Given this list of marker genes SUCLG1, PI4KA, RAB11B, SRPK3, FUCA1, NPC2, ATCAY, GRIN1, NODAL, ATXN1, PRRT2, NDUFA12, NUP54, HPRT1, HIVEP2, SLC25A42, RNU7-1, PLA2G6, STXBP1, VPS16, NDUFA2, SOX10, PI4K2A, DHDDS, NDUFS8, DNAJC13, NEUROD2, FXN (frataxin), OCLN, PIGQ, NAA60, SLC6A3, AFG2A, CLTC, COL25A1, PCCB, COASY (NCBI Gene Id 80347), TWIST1, ADCY5, CHD8, ACSF3, TMEM106B, CDKL5, ATP7B, ATPAF2, HTT, ECHS1, B3GALT6, FOXH1, CLPB, CACNA1B, GABBR2, COPB1, EIF2AK2, SIX3, NDUFAF6, RNASEH2B, ACADS, UFC1, FARS2, ARV1, SIGMAR1, SNORD118, PLCH1, SCN1B, TACSTD2, SETX, LRRK2, SPTAN1, NDUFS7, STX16, PCBD1, SDHD, ATP5PO, NAA10, BSCL2, NADK2, DMXL2, AP3D1, CPLX1, GRIK2, PODXL, GRM7, EARS2, RNASEH2A, TGM6, GLB1, KCNC3, PLAA, CYB5A, GSX2 (NCBI Gene Id 170825), GRIA2, VPS13C, TXN2, ZIC2, DISP1, HACE1, PCGF2, TUBB2B, CACNA1E, WDR73, CUX2, ACTB, SDHA, GLE1, SLC19A3, ALG3, PDHX, CRLS1, SQSTM1, TRIT1, CYB5R3, CEP85L, TMEM240, POLR3A, MICU1, SPTBN1, TGIF1, ALDH6A1, SLC2A1, MMADHC, CACNA1A, LTBP2, H4C5, CHN1, SPG11, MAPT, TRAPPC11, PHLDB1, COL6A3 (NCBI Gene Id 1293), PTCH1, ACER3, PPFIBP1, GCH1, NKX6-2, PRKRA (NCBI Gene Id 94716), HECW2, ATM, EIF4G1, HINT1, MAFB, NDUFS1, TTBK2, MARS2, PRDX3, SHQ1, MPV17, COLEC11, GIGYF2, ARSA, GCDH, FITM2, LIPT1, IFIH1, SLC6A8, MT-ND3, CYP27A1 (cytochrome P450 family 27 subfamily A member 1), TTPA, AP4E1 (NCBI Gene Id 23431), MT-TT, MECR, TUBB4A, SLC2A3, AP4B1, CBS, STARD7, HPDL, ZC4H2, POLR3B, KIF21A, SLC25A22, TRPV4, COL6A1, IMPDH2, KCNN2, ABCD1, ATP5MK, SLC44A1, TRPM3, GNAL, GCSH, FA2H, SPR, CDC40, ATP13A2, CRH, POLR1D, REPS1, CARS2, AFG2B, PSAP, TANGO2, PARK7, TSEN54, AQP4, PPP2R2B, POLR1B, ALS2, PURA, SLC13A5, GRIN2B, POLR3K, KCNA1, ASL, TOR1A, AP4M1, WDR45, FOXG1, SNAPC4, SNCAIP, NDUFAF5, MYF5, TUBB3, DLAT, DNAJC6, DTYMK (deoxythymidylate kinase), VPS41, ACBD6, ACTA1, LSM11, NDUFA9, TRIM8, ATXN8OS, TTC19, REEP1, SCN1A, FGFR1, TCOF1, ROBO3, NGLY1, ESAM, PLP1, STIL, FOXP2, KCNT1, DALRD3, VCP, TAF1, PIGA, SCO2 (NCBI Gene Id 9997), GPRC5B, TSEN34, PRKAR1B, GAD1, UCHL1 (ubiquitin C-terminal hydrolase L1), DNM1L, DRD2, CHRNA4, NDUFS3, XK, SPTSSA, JPH3, FBXO7, PCDH12, PIK3R5, KAT6A, TMEM67, SLC16A2, GM2A, POLR1C, PPIL1, GAS1, DLL1, UBAP2L, PTS, HNRNPH1, HK1, UPB1, ATP5MC3, DNAJC19, FBLN1, CKAP2L, SCP2, CYP2U1, NKX2-1, AFG3L2, PIGP, MT-CYB, CTC1, FLI1, FRMD5, DHX30, ATN1, UFM1, ATP5F1D, TSFM, VAC14, PDHA1, FRRS1L (ferric chelate reductase 1 like), HIBCH, FUS, NAXE, HTRA2, TMEM163, RHOBTB2, LIPT2, TSEN15, FGFR3, VAMP2, GALT, GTPBP2, UBE3C, CNTNAP2, TRAPPC12, GAMT, MRPS34, DRD5, CTCF, GNAS, MTO1, COQ8A, VPS13A, PDE2A, SUPT16H, SDHB, GBA1, GLI2, VPS37A, MYOC, TREX1, IREB2, MOGS, ATAD3A, PDGFB, PRKCG, SHH, HEXB, DEGS1, TACO1, POLG, TNR, PNPLA8, BCAP31, AUH, DLG5, MRE11, ARX, DCAF17, APOE, TBCD, FTH1, STAG2, TH, CNTNAP1, OFD1, GABRB2, SYNJ1, SUCLA2, ECM1, GFM2, MT-CO3, PRDM13, SYNE1, JAM2, LRPPRC, SIK1, PMPCB, PINK1 (PTEN induced kinase 1, NCBI Gene Id 65018), ATP1A2, YY1, RNF170, MT-ND1, ATXN3, DEPDC5, ADAR, SLC30A10, CARS1, MT-ATP8, THAP1, SERAC1, ATG7, SUOX, UQCRQ, VPS11, RNASET2, PHOX2A, SCN8A, ENSG00000288330, COQ9, SH2B1, CASR, UGDH, STN1, GNAO1, ALG9, VAMP1, OGDH, ZNF142, NDUFAF4, MT-ND4, EMC1, MT-TL1, ATP1A3, MT-ND6, SYT1, SURF1, TMEM151A, PNKP, MT-ND2, KCNA4 (NCBI Gene Id 3740), NBEA, SYNGAP1, QDPR, CWF19L1, TGFB2, DDC, ADH1C, COQ2, MMUT, CDON (cell adhesion associated, oncogene regulated), SMC1A, STUB1, MT-ND4L, SAMHD1, B4GALNT1, CHRNA2, MT-ATP6, NR4A2, TMEM63C, CASK (calcium/calmodulin dependent serine protein kinase), SLC20A2, FBXL4, EPRS1, SGCE, COX20, RFX7, HSPG2 (NCBI Gene Id 7796), BCKDK (NCBI Gene Id 94996), APTX, DNAJC12, ITGA7, SEPSECS, AP4S1, CHRNB2, MT-ND5, HPCA, SLITRK2, CRIPTO, COL12A1 (NCBI Gene Id 1304), CLCN4, FGFR2, C19orf12, SLC18A2, PLEKHG2, SLC30A9, MYORG, SCN2A, GJC2, MDH2, PNKD, SLC39A14, GNA11, MECP2, TUBA1A, ANO3, TPI1, MCOLN1, AARS2, SPTLC1, ALG2, ITPR1, POLR1A, COL6A2, SLC1A3, UBA5, CNP, TEK, WARS2, CIZ1, AGTPBP1, FTL, RNASEH2C, SALL4, AARS1, MT-TK, MT-TW, COL4A1, CP, PRKN, AOPEP, SLC39A8, GRIN2A, RNU4-2, PCCA, MED23, BCAS3, TPK1, ATP5F1E, TSPOAP1, KARS1, CYP1B1 (NCBI Gene Id 1545), GNB1, SPOP, SNCA, CABP4, HSD17B10, UBTF, NPC1, CHMP2B, TIMM8A (NCBI Gene Id 84782), VPS4A, IRF2BPL, ATP5F1A, MED27 (mediator complex subunit 27), FGF8, TSEN2, UBQLN2, CDK10, NDUFA6, TBP, GDAP2, PDGFRB, KMT2B, ALDH18A1, YIF1B, SPRED1, COQ4, VPS13D, CACNA1G, SLC35B2, KCNQ2, NAXD, PSEN1, AMPD2, TBC1D24, NEK9, PANK2, VPS35, ACOX1, UBAP1, DCTN1 (NCBI Gene Id 82109), MT-TV (NCBI Gene Id 4577), NTNG1, NHLRC2, MAT1A, KCTD17, DLD, KCNMA1, MRPS25, RARS1, LONP1, NDUFA4, PNPT1, KIF1C, ATXN2, NUP62, SLC32A1, here is a description of the gene set: Dystonia An abnormally increased muscular tone that causes fixed abnormal postures. There is a slow, intermittent twisting motion that leads to exaggerated turning and posture of the extremities and trunk. Human Gene Set: HP_DYSTONIA species: Homo sapiens